The following is a description of a gene set: species: Mus musculus Mouse Gene Set: GOCC_CEREBELLAR_CLIMBING_FIBER_TO_PURKINJE_CELL_SYNAPSE A synapse of a climbing fiber onto the dendrites of a Purkinje cell in cerebellum. The climbing fiber originates from the inferior olivary nucleus of the medulla oblongata., and this is the list of marker genes: Tmem240, C1ql2, Itgb1, Mgll, Sort1, Plxna4, Adgrb3, C1ql1, Grn, Sema3a, Plxnc1 (plexin C1)